Given this list of marker genes ZNF593, AFG2A, GTPBP4, NVL, AFG2B, TMA16, ZNF622, CINP, here is a description of the gene set: studied in species Homo sapiens Human Gene Set: GOMF_PRERIBOSOME_BINDING Binding to a preribosome.